Given this list of marker genes ARCN1, SOCS4, SCGB3A2, EGLN1, DGKH, RAC1, PLAGL2, MCCD1, SLC22A23, SPTLC2, TOX3, ASCC3, PUM2 (pumilio RNA binding family member 2), CAAP1, NFKB1, LRRC8B, COX20, CHMP3, FRMD3 (FERM domain containing 3), CADM1, MAPRE1, NATD1, FOXP2, CWC25, TSHZ2, ZNF638, CELF3, CEBPZOS, VPS13C, CELF4 (NCBI Gene Id 56853), CSTF2T, LNX1, KRT35, ANKMY2, MAP3K2, NUCKS1 (nuclear casein kinase and cyclin dependent kinase substrate 1), ITGB8, CHD6, HOXA5, CACNA2D4, PCDHB4, RNF103-CHMP3, HECTD4, TMEM154, CHRDL1, TMEM169, KDM5A, TMEM116, C17orf67, here is a description of the gene set: Genes predicted to be targets of miRBase v22 microRNA hsa-miR-2909 in miRDB v6.0 with MirTarget v4 prediction scores > 80 (high confidence targets). studied in species Homo sapiens from publication Chen Y, Wang X (PMID 31504780) Human Gene Set: MIR2909